Given this list of marker genes EFCAB7, GSK3B, DZIP1, ENTR1, CROCC, GAS8, CCDC88A, here is a description of the gene set: Human Gene Set: GOBP_POSITIVE_REGULATION_OF_PROTEIN_LOCALIZATION_TO_CILIUM Any process that activates or increases the frequency, rate or extent of protein localization to cilium. species: Homo sapiens